The following is a description of a gene set: Human Gene Set: MATZUK_OVULATION from publication Matzuk MM, Lamb DJ (PMID 18989307) Reproduction is required for the survival of all mammalian species, and thousands of essential 'sex' genes are conserved through evolution. Basic research helps to define these genes and the mechanisms responsible for the development, function and regulation of the male and female reproductive systems. However, many infertile couples continue to be labeled with the diagnosis of idiopathic infertility or given descriptive diagnoses that do not provide a cause for their defect. For other individuals with a known etiology, effective cures are lacking, although their infertility is often bypassed with assisted reproductive technologies (ART), some accompanied by safety or ethical concerns. Certainly, progress in the field of reproduction has been realized in the twenty-first century with advances in the understanding of the regulation of fertility, with the production of over 400 mutant mouse models with a reproductive phenotype and with the promise of regenerative gonadal stem cells. Indeed, the past six years have witnessed a virtual explosion in the identification of gene mutations or polymorphisms that cause or are linked to human infertility. Translation of these findings to the clinic remains slow, however, as do new methods to diagnose and treat infertile couples. Additionally, new approaches to contraception remain elusive. Nevertheless, the basic and clinical advances in the understanding of the molecular controls of reproduction are impressive and will ultimately improve patient care. studied in species Homo sapiens Genes important for ovulation, based on mouse models with female fertility defects., and this is the list of marker genes: SCARB1, LFNG, NR2C2, IL6ST, CEBPB, PDE3A, NRIP1, SIRT1, NOS3, PGR, PDE4D, SULT1E1, PTGS2, LHCGR, YBX2